Given this list of marker genes Becn1, Cisd1, Qtrt1, Qtrt2, Lrrk2 (leucine-rich repeat kinase 2), Grk2 (NCBI Gene Id 11557), here is a description of the gene set: The external (cytoplasmic) face of the mitochondrial outer membrane. Mouse Gene Set: GOCC_CYTOPLASMIC_SIDE_OF_MITOCHONDRIAL_OUTER_MEMBRANE studied in species Mus musculus